Given this list of marker genes DOCK8, PLEKHG3, RICTOR, KRIT1, RUFY3, ARFGEF1, CFL1, KIF20B, LLGL1, RACK1 (NCBI Gene Id 90938), KANK1, SHTN1, RIPOR2, ANKFN1, ROCK1, FLOT2, ABL1, TEK, CDH5, RAP1B, GSN, CYRIB, LLGL2, GATA3, ABL2, ROCK2, IGF1, WDPCP, here is a description of the gene set: Any process that modulates the frequency, rate or extent of the specification, formation or maintenance of anisotropic intracellular organization or cell growth patterns. studied in species Homo sapiens Human Gene Set: GOBP_REGULATION_OF_ESTABLISHMENT_OR_MAINTENANCE_OF_CELL_POLARITY